The following is a description of a gene set: Human Gene Set: GOBP_REGULATION_OF_CALCIUM_ION_TRANSPORT_INTO_CYTOSOL Any process that modulates the rate of the directed movement of calcium ions into the cytosol of a cell. The cytosol is that part of the cytoplasm that does not contain membranous or particulate subcellular components. species: Homo sapiens, and this is the list of marker genes: TRPC3, BAX, ADCYAP1R1 (ADCYAP receptor type I), CAV1, NOS1, EPO, CALCA, P2RX3, BAK1, BCL2, P2RX4, PML, CD4, P2RX7, P2RX5, P2RX2, TMBIM6, ASPH, GRIN1, PLA2G1B